Given this list of marker genes BIRC6, EIF5B, ERLEC1 (NCBI Gene Id 27248), KLHL23, DNAJA2, QKI, GPM6A, GMNN, PIK3C2A, SH3GL3, PDE3A, RADX, UBTD2, HYCC2, C15orf61, GUCY1B1, TMEM196, GABRG1, NHLRC2, PNRC1, FBXO33, SCN2A, ZNF529, EXOC8, SLC44A1, LYSMD3, FAM114A1, TFRC, PURA, LCOR, HSPA14, YEATS2, AKAP13, NPAS3, MEF2D, ZC3H7B, WAC, MORF4L1, TGFBR3, ATP2B3, BMPR1A, USP42, MAGOH, SATB1, ANGEL1, PAFAH1B2, EEA1, DGKH, PTCHD3, UBTF, RBFOX2 (RNA binding fox-1 homolog 2), BMP10, RNF138, SEC22C, SLITRK4, ASPH, HIPK3, SOX9, ARID1A, OTX2 (NCBI Gene Id 5015), BAZ2B, NR2C2, ADAM22, CRISPLD1, SMAD7, LIX1L, CAMKMT, GSE1, DOCK11, GPR137C, UBR1, ADCY7 (NCBI Gene Id 113), KDM3A, ACAP2 (NCBI Gene Id 23527), LAMP2, IRX3, PITPNB, PDE10A, COLEC12, TCF7L2, EPHA5, GPR22, SYT1 (NCBI Gene Id 6857), ZNF486, ACTR6, ARHGEF10L, HERC1, MEIOC, SLC30A5 (solute carrier family 30 member 5), ARID1B, NEIL3, SPOCK3, CASP8AP2 (NCBI Gene Id 9994), RNMT, ZFX (zinc finger protein X-linked), PUM2, BHLHE40, CLCN6, SPOPL, ARMC8, NOTCH2, OLA1, PDGFD, MERTK, MEX3D, ASAH1, PKP1, WDR72, PPM1K, INHBA, TBC1D12, ABHD10, ADAMTS15, CNOT7, NRP1, TRIQK, EXOC1, HNRNPR, HSP90B1, PDS5B, FSTL5, TMTC2, PDE4DIP, SCAI, COL1A1, RGL4, UBE2B, KIAA1217, NUP98, KBTBD8, BICRA, OPA3, NR1D2, CMTM6, BTBD7, GOLIM4, OTUD4, HIVEP1, AFF2, TMOD2 (tropomodulin 2), BTBD3, DENND1B, RAB14, SEPTIN9, TMEM70, TVP23C, RNF220, MSI2, CENPQ, SLC25A31, FGF4, P2RY12, MMP11, CAMSAP2, CNTN1 (NCBI Gene Id 1272), PLCB4, ARHGAP24, CDC73, PPFIA2, MMS22L, CNOT2, IKZF2, PAIP1, BROX, TCEAL7, RASA1, GABRB2, PTPN4, OLFML2B, NANOS1, PTPRE, ERF, NAA20, TVP23B, DDX21, DSC3, SRGAP3 (NCBI Gene Id 9901), CACHD1, SYNJ1, GPATCH11, DEPDC1B, ATP8B1, RAB11FIP3, ABCD3, FOXA1, RFK, CKS2, ZNF280D, NOVA1, TBR1 (NCBI Gene Id 94313), TAF4B, INO80D, ARFGEF2, PTPRR, DYNLL2, ADGRF5, CSRNP3, SECISBP2L, USP1, PDHA1, CTTNBP2NL, CENPN, ASCC3, C2CD5, SLC6A19, CALN1, NR3C1, MAP3K8 (NCBI Gene Id 8040), SNX30, RICTOR, EPB41L5, GATA3, DCUN1D4, PLPP3, ARHGEF9, ZMYM6, TOB1 (transducer of ERBB2, 1), TASP1, DGKD, SFPQ, KIF2A, PCSK2, ARAP2, FHIP2A, TMPRSS12, TMEM132B, NUFIP2 (NCBI Gene Id 57532), ARHGAP20, SBF2, WEE1, SLC38A2, MOB4, ARL2BP, SEMA3C (NCBI Gene Id 222200), MON2, LIPT2-AS1, RAPH1, CLDN12, GP5, LRCH4, PPP4R2, DCUN1D5, PIK3R4, SEH1L, PITX2, RBM5, HHEX, USP32, KIF5B, AJAP1, PLCXD1, JAG1, CCR9 (NCBI Gene Id 2851), TNFAIP8, ARFGAP3, TRHDE, RAB6B, FBXO34, FOXN2 (NCBI Gene Id 3344), SLC1A2 (solute carrier family 1 member 2), HMGXB4, FAM43A, PRR12, UBE3C, ENSG00000255537, WDFY3, ADAMTS5 (NCBI Gene Id 11096), FUT9, TENT4B, APOOL, TXLNG, KLF3, TWIST2, LPA, ZSCAN4, PPM1A (protein phosphatase, Mg2+/Mn2+ dependent 1A), MBTD1, ADAM23, TBRG4, DENND4A, TAOK1, PSME4, ZSWIM6, GTF3C3, LEMD3, HSPE1-MOB4, TLE1, IGF1R, KCNH5, USP24, SPIN1, RLIM, CAPN7, RC3H1, PCTP, PNISR (NCBI Gene Id 84956), ANO1, SH3TC2, TSC22D2 (TSC22 domain family member 2), SPRED1, PLAG1 (PLAG1 zinc finger), MOSMO, STRN, RAD21, TENT5A, SPRY4 (NCBI Gene Id 81848), USP25 (ubiquitin specific peptidase 25), SIRT1, MBNL2, VKORC1L1, ARHGEF12, GABRB3, AKAP6, PDS5A, OTUD6B, LRRN1, CASZ1, PLN, CD81, CCDC80, RBM12B, FZD10, LRP1B, BMPER, RB1CC1, ZNF143, RRAS2, LRP6, VAMP4, ADAM28, HMCN1 (hemicentin 1), ATP6V1A, EBF1, PHB1, MYT1L, SDC2, ST8SIA4, STEAP3, EPHB4, ZNF532, ZNF230, SCAMP1, XRN2, PCDH18, PTPRA, RLIG1, KLHL2, GRB2, SMARCA5, UFM1, CHP1, DIRAS2, GRIA3, CDKN1B, TSHZ3, UBE2H, TPRA1, SLC35E3, PHF13, PPP1R15B, SLAIN2, AAK1 (AP2 associated kinase 1), PUM1, RALGDS, HOXD3, PIK3R1, GRID2, HECTD2, DKK3, PCNX4, ARID4B, FGFR1, HEXIM1, NCKAP1, NFAT5, TAS2R14, PCDHB4, ASCL1, U2SURP, KIF3A, NDFIP2, ITM2B, here is a description of the gene set: from publication Chen Y, Wang X (PMID 31504780) Human Gene Set: MIR4789_5P studied in species Homo sapiens Genes predicted to be targets of miRBase v22 microRNA hsa-miR-4789-5p in miRDB v6.0 with MirTarget v4 prediction scores > 80 (high confidence targets).